The following is a description of a gene set: Human Gene Set: MIR4761_5P species: Homo sapiens from publication Chen Y, Wang X (PMID 31504780) Genes predicted to be targets of miRBase v22 microRNA hsa-miR-4761-5p in miRDB v6.0 with MirTarget v4 prediction scores > 80 (high confidence targets)., and this is the list of marker genes: SNAP91, CD93, MICB, PPP6R3, ANKS4B, ANKIB1, ANK1, CCND2, ZNF468, MTMR4, SH3D19, FOXD4L5, AZGP1, TP53INP2, AZIN1 (NCBI Gene Id 51582), AFF4, CSTF1, FAM124B, GRM1, CNTLN, TIAM1-AS1, ULK1, BMP4, FAM91A1, KLF4, USP6, C15orf32, VSIG1, HMGA2, EMCN, PHF2, ANKRD26, TBC1D10B, SMAD2, PFN2, TBX6, SECISBP2L, CPSF7, UBE2V1, PCDHB5, IMPG2 (interphotoreceptor matrix proteoglycan 2), ATXN2L, ABLIM3, KCTD1, EPHA7, ANKRD6, USP32, ZNF330, ERAL1, GPR3, ITGB6, ANKRD28, FBXO42, ARL4C, STAC, ANXA7, TMCO3, SSH2, PRKAB1, SYNCRIP, ALPI, TMEM170B, PEDS1-UBE2V1, SOBP, AK9, C4orf19, GSE1